The following is a description of a gene set: part of: SLC-mediated transport of amino acids Reactome Pathway: Proton-coupled neutral amino acid transporters This event has been computationally inferred from an event that has been demonstrated in another species.<p>The inference is based on the homology mapping from PANTHER. Briefly, reactions for which all involved PhysicalEntities (in input, output and catalyst) have a mapped orthologue/paralogue (for complexes at least 75% of components must have a mapping) are inferred to the other species. electronically inferred by orthology from the curated human pathway species: Mus musculus, and this is the list of marker genes: Slc36a2 (NCBI Gene Id 246049)